The following is a description of a gene set: species: Homo sapiens DNA copy number amplifications activate oncogenes and are hallmarks of nearly all advanced tumors. Amplified genes represent attractive targets for therapy, diagnostics and prognostics. To investigate DNA amplifications in different neoplasms, we performed a bibliomics survey using 838 published chromosomal comparative genomic hybridization studies and collected amplification data at chromosome band resolution from more than 4500 cases. Amplification profiles were determined for 73 distinct neoplasms. Neoplasms were clustered according to the amplification profiles, and frequently amplified chromosomal loci (amplification hot spots) were identified using computational modeling. To investigate the site specificity and mechanisms of gene amplifications, colocalization of amplification hot spots, cancer genes, fragile sites, virus integration sites and gene size cohorts were tested in a statistical framework. Amplification-based clustering demonstrated that cancers with similar etiology, cell-of-origin or topographical location have a tendency to obtain convergent amplification profiles. The identified amplification hot spots were colocalized with the known fragile sites, cancer genes and virus integration sites, but global statistical significance could not be ascertained. Large genes were significantly overrepresented on the fragile sites and the reported amplification hot spots. These findings indicate that amplifications are selected in the cancer tissue environment according to the qualitative traits and localization of cancer genes. Human Gene Set: MYLLYKANGAS_AMPLIFICATION_HOT_SPOT_25 from publication Myllykangas S, Himberg J, Böhling T, Nagy B, Hollmén J, Knuutila S (PMID 16751803) Amplification hot spot 25: colocalized fragile sites and cancer genes in the 2q13-q36 region., and this is the list of marker genes: ATIC, ERCC3, PAX3, TTL (NCBI Gene Id 150465), FEV, HOXD13, CHN1, HOXD11, PMS1